Given this list of marker genes Washc2, Pla2g4a, Sestd1, Veph1, Plekhf1, Rubcnl, Plcz1, Snx5, Lancl2, Wipi2 (NCBI Gene Id 76581), Plekha5, Sap30l, Sh3pxd2b, Snx3, Sh3pxd2a, Pla2g4e, Phlda3, Snx24, Obscn, Rs1, Jph2, Tom1, here is a description of the gene set: Binding to phosphatidylinositol-5-phosphate, a derivative of phosphatidylinositol in which the inositol ring is phosphorylated at the 5' position. Mouse Gene Set: GOMF_PHOSPHATIDYLINOSITOL_5_PHOSPHATE_BINDING studied in species Mus musculus